Given this list of marker genes Adam5, Spaca3, Adam32, Tex101, Hspa1l, Cct6a, Cct2, Sppl2c, Garin3, Cct7, Fetub, Cct8, Pcsk4, Frey1 (NCBI Gene Id 75641), Adam18, Tmprss12, Dcst2, Zp3r, Zpbp2, Folr2, Dcst1, Tcp1, Glipr1l1, Folr1, Prss37, Pmis2, Cd9, Izumo1, Atp8b3, Izumo1r, Vdac2, Zan, Adam3, Acr, Spa17, Spaca4, Spesp1, Slxl1, Tnp2, Zp3, Cct5, Zp2, Ly6k, Adam1b, Lypd4, Ubap2l, Astl, Aldoa, Adam2, Crisp4, Hspa1b, Zp1, Cct3, Zpbp, Smcp, B4galt1, Arsa, Ovgp1, Tmem81, Prss55, Cct4, Clgn, Adam1a, Spaca6, H1f6, here is a description of the gene set: Mouse Gene Set: GOBP_SPERM_EGG_RECOGNITION species: Mus musculus The initial contact step made between the sperm plasma membrane and outer layer of the egg during fertilization.